The following is a description of a gene set: A protein complex that is composed of AKTIP/FTS, FAM160A2/p107FHIP, and one or more members of the Hook family of proteins, HOOK1, HOOK2, and HOOK3. The complex is thought to promote vesicle trafficking and/or fusion, and associates with the homotypic vesicular sorting complex (the HOPS complex). Mouse Gene Set: GOCC_FHF_COMPLEX species: Mus musculus, and this is the list of marker genes: Fhip1b, Aktip, Hook3, Hook1, Hook2